The following is a description of a gene set: species: Mus musculus Any process that modulates the frequency, rate, or extent of antigen processing and presentation of antigen (peptide or polysaccharide) via MHC class II. Mouse Gene Set: GOBP_REGULATION_OF_ANTIGEN_PROCESSING_AND_PRESENTATION_OF_PEPTIDE_OR_POLYSACCHARIDE_ANTIGEN_VIA_MHC_CLASS_II, and this is the list of marker genes: Pycard, H2-Ob, H2-Oa (histocompatibility 2, O region alpha locus), Thbs1, Trem2